The following is a description of a gene set: studied in species Mus musculus Mouse Gene Set: GOBP_POSITIVE_REGULATION_OF_PEPTIDYL_LYSINE_ACETYLATION Any process that activates or increases the frequency, rate or extent of peptidyl-lysine acetylation., and this is the list of marker genes: Prkaa2, Dip2a, Sox4, Pml (promyelocytic leukemia), Nfe2, Dip2b, Prkaa1